Given this list of marker genes BLM, JAK1, CDC25A, NOXA1, BARD1, MIR29B1, SMAD3, MYC, MIR29B2, CDK4, CDK1, ATF1, STAT1, MSH6, CDKN1B, MSH2, CDKN1A, CDK2, CASP9, RAD50, BAX, BRCA1, POU2F1, MDM2, CHEK1, E2F1, MRE11, PTEN, CDKN2B, ATR, SMAD2, RB1, MMP1, MIR29C, MIR21, CASP8, CASP3, CHEK2, ATM, BCL2, MAP3K5, PLK1, TP53 (NCBI Gene Id 7157), BAD, AKT1, BACH1, CDC25B, BBC3, here is a description of the gene set: Integrated cancer pathway studied in species Homo sapiens Human Gene Set: WP_INTEGRATED_CANCER_PATHWAY